The following is a description of a gene set: species: Mus musculus Mouse Gene Set: GOBP_C21_STEROID_HORMONE_BIOSYNTHETIC_PROCESS The chemical reactions and pathways resulting in the formation of C21-steroid hormones, steroid compounds containing 21 carbons which function as hormones., and this is the list of marker genes: Hsd3b6, Hsd3b2, Cyp11a1, Stard3, Dab2, Cyp11b1, Egr1, Dgkq, Scp2, Cacna1h, Clcn2, Bmp6, Cyp21a1, Cyp11b2, Wnt4, Cyp27a1, Ppargc1a, Bmp5, Dkk3, Rest, Hsd3b3, Bmp2